Given this list of marker genes GOT1, GLS (NCBI Gene Id 51679), MTHFD1, MTHFD1L, GLS2, GOT2, HAAO, IDO1, GLUD2, KMO, GOT1L1, ACMSD (aminocarboxymuconate semialdehyde decarboxylase, NCBI Gene Id 130013), KYNU, GLUD1, here is a description of the gene set: The chemical reactions and pathways resulting in the formation of dicarboxylic acids, any organic acid containing two carboxyl (-COOH) groups. Human Gene Set: GOBP_DICARBOXYLIC_ACID_BIOSYNTHETIC_PROCESS species: Homo sapiens